The following is a description of a gene set: species: Homo sapiens Human Gene Set: HP_ESOPHAGEAL_NEOPLASM Esophageal neoplasm A tumor (abnormal growth of tissue) of the esophagus., and this is the list of marker genes: SDHC, COL4A5, COL14A1, STAT1, RAD21, APC, DCC, LZTS1, CTHRC1, PDE11A, SDHB, TGFBR2, ASCC1, BLM, PDGFRA, RNF6, PRKAR1A, STK11, SDHA, MSR1, COL4A6, MYH11, RHBDF2, WWOX, KIT, AAGAB, FH, DLEC1